The following is a description of a gene set: Globins are heme-containing proteins that reversibly bind molecular oxygen. Humans contain at least 5 types of globins: hemoglobins, myoglobin, cytoglobin, neuroglobin, and androglobin. Myoglobin, neuroglobin, and cytoglobin are cytosolic globins with similar affinities for oxygen. Androglobin is a more distantly related globin of uncertain function that is expressed in testes. Myoglobin is predominantly expressed in muscle tissue, neuroglobin is expressed in neurons, and cytoglobin is expressed in connective tissue fibroblasts and smooth muscle cells. Whereas myoglobin contains pentacoordinated heme iron, neuroglobin and cytoglobin contain hexacoordinated heme iron: the iron atom is bound by 4 nitrogen atoms of heme and 2 histidine residues of the globin. Binding by one of the histidines is reversible, which allows the iron atom to bind various ligands such as molecular oxygen, carbon monoxide, and nitric oxide. Neuroglobin may function in oxygen homeostasis, however the importance of its oxygen-binding activity is unclear. Cytoglobin may function in nitric oxide metabolism. Globins can also regulate oxygen homeostasis via reactions with nitric oxide (NO), a vasodilator. Oxygenated globins scavenge NO by oxidation while deoxygenated globins can act as a nitrite reductase to produce NO. part of: Transport of small molecules studied in species Homo sapiens Reactome Pathway: Intracellular oxygen transport, and this is the list of marker genes: NGB, CYGB, MB